Given this list of marker genes S100a8, Angptl4, Fcgr3, Iigp1 (interferon inducible GTPase 1), Akap12, Steap4, Sfn, Lox, Klf6, Tgfbi, Lcn2, Spp1, Txnrd1, Dusp1, Litaf, Ccn1, Mcl1, Fos, Klhl2, Ndufs1, Zfp36, Serpina3g, Ltf, Myc (myelocytomatosis oncogene), Slfn4, Ptges, Col3a1, Eln, Tnc, Osmr, Nfkbia, Btg2, Cdkn1a, Retnlb, Sphk1, Pla2g7, Ltbp1, Ptx3, Rbm3, Nr4a1, Lrg1, Lilrb4b, Tpm1, Serpind1, Mal, Or4e1, Cstb, Eif1a, here is a description of the gene set: species: Mus musculus Mouse Gene Set: MCDOWELL_ACUTE_LUNG_INJURY_UP The role of nitric oxide (NO) in acute lung injury remains controversial. Although inhaled NO increases oxygenation in clinical trials, inhibiting NO-synthase (NOS) can be protective. To examine the latter, nickel-exposed mice were treated with saline or NOS inhibitor, N(G)-nitro-L-arginine methyl ester (L-NAME). Initial microarray analysis of nickel-induced gene expression of saline-treated mice revealed increased inflammatory mediator, matrix injury-repair, and hypoxia-induced factor-mediated sequences and decreased lung-specific (e.g., surfactant-associated protein B and C) sequences. Compared with saline control, L-NAME-treated mice had enhanced survival with attenuated serum nitrate/nitrite, endothelial NOS activity, and lavage neutrophils and protein. Although initial cytokine (i.e., interferon-gamma, interleukins-1beta and -6, macrophage inflammatory protein-2, monocyte chemotactic protein-1, and tumor necrosis factor-alpha) gene expression was similar between groups, subsequent larger cytokine increases only occurred in saline-treated mice. Similarly, surfactant protein gene expression decreased initially in both groups yet was restored subsequently with L-NAME treatment. Interestingly, the role of inducible NOS (iNOS) in these responses seems minimal. iNOS gene expression was unaltered, iNOS activity and nitrotyrosine residues were undetectable, and an iNOS antagonist, aminoguanidine, failed to increase survival. Rather, systemic L-NAME treatment appears to attenuate pulmonary endothelial NOS activity, subsequent cytokine expression, inflammation, and protein permeability, and thereby restores surfactant gene expression and increases survival. from publication McDowell SA, Gammon K, Zingarelli B, Bachurski CJ, Aronow BJ, Prows DR, Leikauf GD (PMID 12540486) Genes up-regulated in the mouse model of acute lung injury induced by inhaling nickel sulfate.